Given this list of marker genes MOG, CTSH, DNMT1 (NCBI Gene Id 1786), HLA-DRB1, ZNF365, HLA-DQB1, HCRT, P2RY11, TNFSF4, TRANK1, here is a description of the gene set: Abnormal hypnagogia Human Gene Set: HP_ABNORMAL_HYPNAGOGIA species: Homo sapiens Abnormal transition of consciousness from wakefulness to sleep.